Given this list of marker genes KAT2B, CCN1, VASP, TGFB3, SMARCA4, SLIT3, FN1, ATAD2, COL3A1, COL5A1, ABI1, OPHN1, CXCL17, MMP13, AOC3, here is a description of the gene set: Cancer and embryonic stem cells exhibit similar behavior, including immortal, undifferentiated, and invasive activities. Here, we show that in clinical samples bladder tumors with intense expression of stem cell marker Oct-3/4 (also known as POU5F1) are associated with further disease progression, greater metastasis, and shorter cancer-related survival compared with those with moderate and low expressions. Expression of Oct-3/4 is detected in human bladder transitional cell carcinoma samples and cell lines. Overexpression of Oct-3/4 enhances, whereas knockdown of Oct-3/4 expression by RNA interference reduces, migration and invasion of bladder cancer cells. Oct-3/4 can up-regulate fibroblast growth factor-4 and matrix metalloproteinase-2 (MMP-2), MMP-9, and MMP-13 production, which may contribute to tumor metastasis. Finally, we show that Ad5WS4, an E1B-55 kD-deleted adenovirus driven by the Oct-3/4 promoter, exerts potent antitumor activity against bladder cancer in a syngeneic murine tumor model. Therefore, our results implicate that Oct-3/4 may be useful as a novel tumor biological and prognostic marker and probably as a potential therapeutic target for bladder cancer. studied in species Homo sapiens Genes up-regulated by POU5F1 in bladder cancer cell lines. from publication Chang CC, Shieh GS, Wu P, Lin CC, Shiau AL, Wu CL (PMID 18676852) Human Gene Set: CHANG_POU5F1_TARGETS_UP